The following is a description of a gene set: Human Gene Set: GOMF_KINASE_ACTIVITY Catalysis of the transfer of a phosphate group, usually from ATP, to a substrate molecule. studied in species Homo sapiens, and this is the list of marker genes: PRKCB, RIOK2 (NCBI Gene Id 55781), CCL3, PHKG2 (NCBI Gene Id 5261), MTOR, MAP2K4, DGKH, MAP3K14, HEXIM2, MAST1, MBIP, PIK3C2G (phosphatidylinositol-4-phosphate 3-kinase catalytic subunit type 2 gamma), RYK, LTBP1, GAK, PRKD2, STK36, SPEG, ANKRD54, KSR2, TLK1, ATAD3A, CDK4 (cyclin dependent kinase 4), PPIP5K1, NEK2, FERMT2, STK40, MAPK14, IP6K1, TGFBR3, ERBB3, NME2, MLST8, CCNH, SGMS1, APC, EPO, EPHB4, IP6K2, STK33, STK39, CAMKK1, MAPK8IP1, CKMT1B, PRKD3, HSPB8, MAP3K6, GPRC5C, INCA1, CLK1, ROCK2, ACVRL1, CAMKV, DUSP19, DBF4, WEE1, TNNI3K, CDKL4, CCND2, SPHK1, TOP1, GSK3B, SAV1, PRKAR2A, LAMTOR3, TAOK1 (NCBI Gene Id 80214), CDKN1A, TOM1L1, PEAK3, RIPK2, OBSCN, CAMK1, DLG1, PARVA, VRK2, KDR (NCBI Gene Id 3791), PIK3CA, TESC, TREM2, PHKG1, COQ8B, NAGK, MINK1, MAK, PFKFB1, TTK, ACVR1C, BMP2 (bone morphogenetic protein 2), RPS6KA3, MASTL, SMO, PARP8, DAZAP2, MAPK6, GDF2, MT3, HIPK4, CD40LG, PHKA2, PRP4K, SMCR8, PAK6, UCK1, MPP1, WNK4, ATP23, PKDCC, DCAKD, DAXX, SPHK2, CCNA2 (cyclin A2), PANK1, SRMS, ALPK3, ERN2, CKS2, MOB3B, RPS6KB1, PRKDC, SBK1, WASHC1, UCKL1 (uridine-cytidine kinase 1 like 1), ITK (IL2 inducible T cell kinase), ROR2, NCKAP1L, TKFC, PIP4K2C, CCNJ, SCYL3, PIK3R3, AKT3, PDGFRB, PFKFB4, SMG1, CDC42BPB, HKDC1, HK1, EIF2AK3, CAMK2D, RPS6KA5, AURKC, IBTK, CHUK, GRK4, CDK20, SIK2, HUNK, N4BP2, MACROH2A1, INSRR, MKNK2, PANK3, CDK19, RANBP2, RHOH, PIP4K2A, IDNK, AAK1, GRK6, MAST3 (NCBI Gene Id 23031), PKN1 (NCBI Gene Id 5585), CCL5, BMX, PKIG, MYLK3, MAP4K4, CDKN2A, RICTOR, DDR1 (discoidin domain receptor tyrosine kinase 1), ROR1, AK3, NRBP2, DGUOK, UHMK1, STK10, YES1, EPHA5, MAP3K19, MAP2K1, LIMK1, PRKAG2, STRADB, BMPR1A, HMGB1, NEK9, NTRK3, FLT3, TRIB3, EPHB6, PRKCZ, RIPK4, CPNE3 (NCBI Gene Id 8895), HIPK2, NME2P1, CAMK2B, SGMS2, MAP2K3, STK26, PIK3R5, RPS6KA6, AXIN1, TOPBP1, MAPK8, CDC42BPA, WEE2, ITPK1, DLG2, TESK1, TK1, NME1, NIM1K, CAMK1G, OXSR1, DGKG, JAK1, STK17B, ADCK2 (NCBI Gene Id 90956), PLK2, FLT1, FCSK, PGK2, PIK3IP1, VEGFA, NPR2, MAP3K15, PGK1, NADK2, DGKA (NCBI Gene Id 1606), CCL2, MAPK8IP2, DOLK, MAPKAPK3, CIB1, RASSF2, PTK6, NRBP1, DGKK, CDKL5, STK24, CDK2, SPRY4, PTK7, AKT1S1, PKM, HTATIP2, DAPK1 (death associated protein kinase 1), CILK1, AK4, SEPHS1, CDK18 (cyclin dependent kinase 18), CAV1, KALRN, FN3K, CHKB, PRPS2, FER, EIF2AK1, PIM2, ZAP70, CMPK1, EFEMP1, GCKR, PSKH2, RIOK1, EPHA6, SRC, CALM2, AJUBA, AK6, STRADA, ERCC6, MAPK3, EPHA10, NME5, RPS6KC1, MAPK15, SYK, COQ8A, TSSK1B, PMVK, CCNG1, PRKAR2B, PNCK, GALK1, ANKRD42, TTN, CIT, NGF, MTCP1, GUCY2C, NME6, PNKP, DYRK4, DGKD, CDK5R2, EEF2K, NEK4, PIP5K1C, RGCC, KIDINS220, PRKCE, PREX2, PRKCQ, GALK2, CCNI2, YWHAB, XYLB, TGFA, GPRC5B, WDR91, ROS1, DCLK2, STK32A, CCNK, CAMK4, MUSK, CSNK1A1L, ERN1, NEK5, TRIB2, MARK1, CDKN2B, IRAK4, PGM2L1, MAST2, MATK, DCLK1, PRKD1, CDKN1B, NOL9 (NCBI Gene Id 79707), PDK2, LTF, BRD4, AGK, PKIA, MST1R, ACVR1B, ALPK1, EEF1A1, RFK, DAPK3, PIK3C3, AK2, GRM5, CLP1, CSNK2B, DCK, MAP3K9, ATG14, TSSK6, AVP, PPP1R9B, PKIB, CEP43, MAPK7, NRK, CSNK1G2, EIF2AK2, PI4K2A, DAB2IP, DGKI, FN3KRP, AK1, PASK, BRD2, MAPKAPK2, IQGAP1, GNE, KLF4, NT5C2, MARK2, MAP3K21, HTR2A, EPHA8, CXCL10, GMFG, CDKN2D, CDK16, FGR, GSK3A, TPK1, MAST4, IL2, CERK, EFNA5, ALK, PAPSS1, NRG1, HSP90AB1 (heat shock protein 90 alpha family class B member 1), CDK10, TRPM7, GRK1, PRKAG3, BCR, EFNB3, PDK3, FASTK, SOCS1 (NCBI Gene Id 8651), LIMK2, DGKE (diacylglycerol kinase epsilon), MAP3K4 (mitogen-activated protein kinase kinase kinase 4), ATR (ATR serine/threonine kinase), MAP2K2, PRKY, STK25, ANKK1, RET, BLK, CD24, TGFB1, MAGI3, CARD11, CCNL1, MAPRE3, PAK1, ALKAL2, MOB2, CDK15, MOK, FGFRL1, SH3BP5L, ANKLE2, EPHA2, CDK1, SRPK2, PAK5, KHK, DUSP22, TK2, IGF1R, NBN, CERKL, MAP4K5, YWHAG, SRPK3, PRKCG, LRRK2, MYO3B, CDK11B, DUS2, MOB1B, RAD50, PRKAA2, VRK1, ITPRIP, NME7, NPR1, CKMT1A, PXK, TTBK2, PCK1, CAB39, EIF2AK4 (NCBI Gene Id 440275), DCAF1, MAPK11 (NCBI Gene Id 5600), PIK3CB (phosphatidylinositol-4,5-bisphosphate 3-kinase catalytic subunit beta), DGKB, PPP5C (NCBI Gene Id 5536), MYLK4, GCK, CSNK2A1, CHKA, TP53RK, TSSK4, BRSK2, CDK12, TAF1, INKA2, MAP2K7, ARAF, AURKB, ETNK2, HCK, CNPPD1, CLK3, AK5, PAK2, SOSTDC1, ETNK1, PIP5K1A (phosphatidylinositol-4-phosphate 5-kinase type 1 alpha), PAK1IP1, PRKACB, STK19, TESK2, TPX2, PTK2B, JAK2, CDK3, PIK3C2A, ABL2, ATM, LATS2, GUK1, STK31, RAC2 (NCBI Gene Id 5880), SPRY2, TRIM24 (tripartite motif containing 24), QARS1, CLK4, TYK2, FAM20C (NCBI Gene Id 56975), MADD, HTRA2, CDKL1, PRKX, STK38, MAP2K5, RIPK3 (NCBI Gene Id 11035), HK3, PPP1R1B (protein phosphatase 1 regulatory inhibitor subunit 1B), CSF1R, NRP1, RPLP1, NEK7, MOB3C, EPHA1, TIE1, CMPK2, NME4, CAMK2N1, SH3BP5, PRKRA, ROCK1, GRK2, IL6ST, CCNA1, DNAJC3, LATS1 (NCBI Gene Id 9113), ATG13, CAMK2G, CHEK1, PSTK, LCK, PI4K2B, PIM1, STK3, TEC, MAP3K12, SPRED1, CCNB2, PDGFRL, CKM, CAMK2A, HSPA5, CCDC88A, BRSK1, MSTN, PRKACA, PANK2, ALS2, FYN, IGF1, CKMT2, CKS1B, EREG, C8orf44-SGK3, MAP2K6, PIK3R4, TGFBR3L, PANK4, TXK, STKLD1, RHEB, SBK2, AURKA, CCNF, DDX3X, CSNK2A3, TRIO, ADIPOQ, TBCK, ADPGK, PREX1, GRK5 (G protein-coupled receptor kinase 5), GMFB, GHRL, CCKBR, DYRK1A (dual specificity tyrosine phosphorylation regulated kinase 1A), STK17A, SGK1, ACVR2A (NCBI Gene Id 92), CCNB3, SAMD15, WNT11, MAP3K5, SOCS3, SH3GLB1 (SH3 domain containing GRB2 like, endophilin B1), COASY, DAPK2, CCNQ, PRKCA (NCBI Gene Id 5578), BRD3, NPM1, NMRK2, PIM3 (Pim-3 proto-oncogene, serine/threonine kinase), PIK3R6, JAK3, CAB39L, CCNE2, DMPK, BMP2K, AK7, DYRK2, GUCY2D, PDE8A, TRIB1, LTBP4, PRKCI (protein kinase C iota), GDF10, ADK, MOS, AATK, HSPB1, SRPK1, NUAK2, NEK6 (NCBI Gene Id 58167), SFN, CCNT2, AXL, LILRB4, CDC7, PLK1, EPHB3 (EPH receptor B3), CCND3, LRP6, EPHB1, PRKG2, NEK3, UCK2, TNIK, FAM20B, STK16, PPEF2, ITPKC, CERT1, TEX14, SIK3, CDK5R1, IKBKB, RBKS, GUCY2F, PINK1 (PTEN induced kinase 1), WNK2, PTPRC, PFKP, ACSL1, CCNI, CSNK1E, PDK4, PAPSS2, SGK2, MAPKAPK5, MAPK1, CSK, SGK3, CCNB1, TSSK3, HIPK1, LMTK2, PRKG1, CCNP, PRKRIP1, CSNK1G1, CDK7, HYKK, INSR, ITPKA, AKT2, TBK1, HBEGF, AREG, BMPR1B, GPRC5A, PRKAR1A, MMD, RPS6KA1, CDK14, SPRED2, STK11, MAP3K20, CSNK1A1, PFKFB2, IRAK2, CDK8, MERTK, SPDYA, UPRT, AMHR2, PIP4K2B, MAP3K8, CCL8, NUAK1, GREM1, RPS6KA2, TAB1, PARP16 (poly(ADP-ribose) polymerase family member 16), PI4KA, CDC37, MAP3K7, CCNY, TNK1, MYLK, MAP3K3 (NCBI Gene Id 4215), HIPK3, GSTP1, PRKAR1B, PTK2 (protein tyrosine kinase 2), BAZ1B, MAPK4, NME9, NLK, PLK4, CAMKK2, STK35, STAP1, NTRK2, BMP7, HEXIM1, MAPK10, GHR, IPPK, IRS2, TAOK2, PRKAG1 (NCBI Gene Id 5571), FRK, DELE1, IRAK1, NEK1, CDKL3, MAP3K1, PPIP5K2, PIP5KL1, PYDC1, IPMK, EFNA3, NEK8, TAOK3, WNK1, CALM1, TLK2 (NCBI Gene Id 11011), CSNK1G3, MAPK9, GK5, RPTOR, CCNG2, MAP4K1, FES, TNKS1BP1, GCN1, GLYCTK, PEAK1, ABI1, INKA1, PDXK, PKLR, MKNK1, BCKDK, PAK4, GRK3, PPP2R5A, KSR1, PAK3, VRK3, TGFBR2 (transforming growth factor beta receptor 2), GRK7, DGKZ, TCL1A, AHSG, EPHA7, SHPK, WNK3 (NCBI Gene Id 65267), PIP5K1B, MAP3K11, SLC27A1, ELP4, PIK3CD, CLK2, SCYL2, CDK5, PKN3, DUSP3, KAT2B, BCL10, LMTK3, RPS6KL1, ULK3, CCNJL, IGF2, PSKH1, DCLK3, AK9, CCNO, PFKL, PLK5, CCNC, PIK3R2, ITPKB, EPHB2, PFKM, IKBKE, NEK11, HJV, HYAL2, PARP6, IGF2R, ULK1, AKT1, MAPK12, FAM20A, CCND1, EPGN, DYRK1B, WDR81, MAPK13, FGFR1, BRAF, PIK3C2B, CCNE1, GK2, PRKACG, TGFBR1 (transforming growth factor beta receptor 1), RUBCN, MVK, PRPS1L1, MOB3A, DSTYK, DEPTOR, EGF, CDC42BPG, CDK11A, FGFR3, NMRK1, GSKIP, PPM1D, CASP3, BMPR2, BRDT, SEPHS2, MMD2, IP6K3, CDKL2, ACVR1, PRPS1, STK32C (NCBI Gene Id 282974), CDKN1C, CDK9, PMS2P11, SNRK, AGAP2, SPEGNB, RIOK3, CAMK2N2, STK38L, AK8, GPRC5D, ERBB4, FGFR4, MET, NME3, IRAK3, SIK1, PRKAB2, CSNK2A2, MAP4K3, DGKQ, TRRAP, LRGUK (leucine rich repeats and guanylate kinase domain containing), TEK, MALT1, BTC, BTK, CASK, PDPK1, PDK1, MNAT1, ALDH18A1 (aldehyde dehydrogenase 18 family member A1), CDK13 (NCBI Gene Id 8621), KIT, EPHA4, LYN, NRP2, BUB1, SCYL1 (SCY1 like pseudokinase 1), CDK6, TTBK1, PFKFB3, DYRK3, SNCA, DBF4B, PDIK1L, NCK1, HASPIN, DTYMK, ERBB2, ILK, ULK4, BUB1B, GK (NCBI Gene Id 2710), MARK3, FLT4, CAD, NADK, ADCK1, MAP4K2, TRIM28, CCNT1, PKMYT1, ACVR2B, RPS6KB2, ADCK5, MLKL, POMK, PKN2, CIITA, PRAG1, BCCIP (BRCA2 and CDKN1A interacting protein), STK32B (serine/threonine kinase 32B), PHKA1, ETAA1, NEK10, PRKAA1, TWF1, PIK3CG, TJP2, FGFR2, ULK2, TAF1L, CRIM1, ALPK2, EGFR, STK4, EPHA3, PIK3R1, ANGPT4, TCL1B, CKB, NTRK1, MAP3K13, MYO3A, FAF1, RNASEL, MYLK2, AFAP1L2, TSSK2, LRRK1, PIPSL, PI4KB, RIPK1, MAP3K10, MOB1A, HK2, PBK, RACK1, CHEK2, IRGM, CDKN2C, CSNK1D, LTK, TRPM6, STYK1, CDK17, CHP1 (calcineurin like EF-hand protein 1), BMP4, PI4KAP2, DDR2, MARK4, WARS1 (tryptophanyl-tRNA synthetase 1), ELP3, CAMK1D, RPS6KA4, PAN3, SLK, MELK, CALM3, PMS2P1, MAP3K2, PRKCD, SBK3, RSKR, ALKAL1, ABL1, PRKCH, RAF1, PLK3, NRG3, EFNA4, TYRO3, CCNL2, PDGFRA, FGGY, TNK2, PIKFYVE